The following is a description of a gene set: mTORC1-mediated signalling species: Mus musculus Mouse Gene Set: REACTOME_MTORC1_MEDIATED_SIGNALLING, and this is the list of marker genes: Rptor, Rheb, Lamtor1, Fkbp1a, Akt1s1, Rps6, Rraga, Mtor, Slc38a9, Ywhab, Rragb, Eif4g1, Eef2k, Eif4b, Lamtor4, Lamtor2, Rps6kb1, Lamtor5, Lamtor3, Rragd, Eif4e, Rragc, Eif4ebp1, Mlst8